Given this list of marker genes ABCD1, ACAA1, ACBD4, SLC25A17, ACOX2, MLYCD, CROT, EHHADH, SLC27A2, ACOX3, ACOXL, CRAT, ALDH3A2, ACOT8 (acyl-CoA thioesterase 8), PECR, HSD17B4, ACOX1, HAO2, AMACR, ACOT4, SCP2, NUDT19, NUDT7, ECI2, PHYH, ACBD5, HACL1, DECR2, here is a description of the gene set: studied in species Homo sapiens Human Gene Set: REACTOME_PEROXISOMAL_LIPID_METABOLISM Peroxisomal lipid metabolism